The following is a description of a gene set: Neighborhood of STAT6 signal transducer and activator of transcription 6, interleukin-4 induced in the GNF2 expression compendium studied in species Homo sapiens Human Gene Set: GNF2_STAT6 Neighborhood of STAT6, and this is the list of marker genes: STAT6, INPP5D, FXYD5, TUT7, MYD88, GRK6, WAS, ADPGK, ACTR2, TGFB1, VAV1, HLA-B, ARF6 (ADP ribosylation factor 6), ARPC1B (NCBI Gene Id 10095), CAPZA1, SNAP23, HCLS1, HLA-F, TYK2, LSP1, BNIP2, EMP3, CD48, DAZAP2, TCIRG1, RAC2, ARPC3, CYBA, LAPTM5, SELL, ARPC2, SEC11A, PRR13, LAT2 (linker for activation of T cells family member 2), CORO1A, FMNL1, ACTR3, ACAP2, CAP1, GIT2, HLA-G, GPSM3, DOCK2, CYBC1, CASP4, OSTF1, MSN, PSMB8, HLA-A, TAPBP, EVI2B, B2M, USP3, GMIP, LYN, HLA-C, ANXA11, CD53, ICAM3, PTPN6, ELF4, ARHGDIB (Rho GDP dissociation inhibitor beta), CLIC1, CORO7, TRIM38, MBD2, SERP1, PSMB10 (proteasome 20S subunit beta 10), HLA-E (major histocompatibility complex, class I, E), CMTM6, ARPC5, RIN3, LCP1, LRRFIP1, IQGAP1 (NCBI Gene Id 8826, IQ motif containing GTPase activating protein 1), RNASET2, JUNB, PAK2, MOB1A